Given this list of marker genes LGI4 (NCBI Gene Id 163175), LGI3, CACNG3, LGI2, CACNG4, DLG4, ADAM23, ADAM22, CACNG2, LGI1, CACNG8, STX1A, STX1B, ADAM11, here is a description of the gene set: part of: Developmental Biology studied in species Homo sapiens Synapse formation and maturation require multiple interactions between presynaptic and postsynaptic neurons. These interactions are mediated by a diverse set of synaptogenic proteins. Initial synapse formation needs both the binding of secreted proteins to presynaptic and postsynaptic receptors, and the direct binding between presynaptic and postsynaptic transmembrane proteins. One class of molecules that plays an important role in cellular interactions in nervous system development and function is the leucine-rich glioma inactivated (LGI) protein family. These are secreted synaptogenic proteins consisting of an LRR (leucine-rich repeat) domain and a epilepsy-associated or EPTP (epitempin) domain. Both protein domains are generally involved in protein-protein interactions. Genetic and biochemical evidence suggests that the mechanism of action of LGI proteins involves binding to a subset of cell surface receptors belonging to the ADAM (a disintegrin and metalloproteinase) family, i.e. ADAM11, ADAM22 and ADAM23. These interactions play crucial role in the development and function of the vertebrate nervous system mainly mediating synaptic transmission and myelination. Reactome Pathway: LGI-ADAM interactions